Given this list of marker genes Hpse, Ednrb, Ednra, Idua, Angpt1, Slc10a7, Ndst2, Naglu, Ext2, Glce, Ndst4, Ndst3, Edn1, Xylt2, Hs2st1, Ndst1, Ext1, here is a description of the gene set: species: Mus musculus The chemical reactions and pathways involving heparin proteoglycans, which consist of a core protein linked to a heparin glycosaminoglycan. The heparin chain is composed of the repeating disaccharide unit beta-(1,4)-N-acetyl-D-glucosamine-alpha-(1,4)-hexuronic acid, the former being either sulfated or deacetylated on its amino group as well as sulfated on one of its hydroxyl groups, and the latter being e a mixture of sulfated and nonsulfated D-glucuronic and L-iduronic acids. Heparin is similar to heparan sulfate but it contains more N-sulfate and O-sulfate groups. Heparin proteoglycans are stored selectively in the secretory granules of mammalian mast cells. Mouse Gene Set: GOBP_HEPARIN_PROTEOGLYCAN_METABOLIC_PROCESS